Given this list of marker genes MECOM, LHX1, HOXB4, PCDH19 (NCBI Gene Id 89774), ID4, FGF2 (fibroblast growth factor 2), PLAC8, PAX2, BMP4, RET, GATA3, CTNNB1, PAX8, HOXA6, EMX2, NPNT, OSR1, WFDC2, here is a description of the gene set: The nephric duct originates from nephrogenic cords of intermediate mesoderm by a transition of the cells to epithelium in response to signals from somites and overlying ectoderm. Initially, the nephric duct forms within in the pronephros, the first kidney structure, which comprises the nephric duct (the pronephric duct at this time) and connected tubules that empty into it. The second kidney structure, the mesonephros, then forms at the caudal end of the pronephros and contains a segment of the nephric duct, the mesonephric duct (also called the Wolffian duct), with connected proximal and distal tubules attached to nephrons and vascular glomeruli. The mesonephros fuses with the cloaca and contributes to the urinary bladder.<br>The metanephros then forms and persists as the functional adult kidney. The metanephros originates by the initiation of the ureteric bud from of the caudal end of the mesonephric duct, a process that is driven by molecular interactions between the nephric duct and the adjacent metanephric mesenchyme. The ureteric bud then branches and about a million nephrons, the functional filtration units of the kidney, are formed at the ureteric bud tips by an interaction between the ureteric bud and the metanephric mesenchyme. <br>The position of kidney formation is determined by the retinoic acid gradient acting through the HOXB4 homeobox transcription factor (inferred from mouse embryos in Preger-Ben Noon et al.2009, reviewed in Marcotte et al. 2014). PAX2, PAX8, and LHX1 are expressed early during the formation of the intermediate mesoderm. Subsequently, expression of LHX1 becomes restricted to the developing renal progenitors and is maintained by PAX2 and PAX8 (inferred from mouse homologs in Boualia et al. 2013). In the developing nephric duct, LHX1 acts with PAX2 and GATA3 to form a self-reinforcing regulatory module based on the mutual activation of LHX1 and GATA3 that drives formation of the nephric duct of the pronephros and mesonephros (inferred from mouse homologs in Boualia et al. 2013, reviewed in Marcotte et al. 2014). LHX1, GATA3, PAX2, and PAX8 then activate several genes involved in differentiation of the nephric duct including EMX2, EVI1, ID4, PLAC8, WFDC2, PCDH19, Nephronectin (NPNT), and the receptor tyrosine kinase RET. Subsequent formation of the ureteric bud is regulated by the interaction between GDNF from the metanephric mesenchyme and RET (inferred from mouse homologs in Majumdar et al. 2003) and the interaction between integrin alpha8/beta1 (ITGA8) from the metanephric mesenchyme and NPNT (inferred from mouse homologs in Brandenberger et al. 2001). Reactome Pathway: Formation of the nephric duct part of: Kidney development species: Homo sapiens